Given this list of marker genes CLIC6, SPINK1, APOE, NR6A1, CA4, S100G, AFP, SLC2A3, APOOL, TTR, APOA1, EMB, TCFL5, KRT18, SLC2A1, LGMN, APOM, here is a description of the gene set: from publication van de Sluis B, Muller P, Duran K, Chen A, Groot AJ, Klomp LW, Liu PP, Wijmenga C (PMID 17371845) species: Mus musculus Human Gene Set: VANDESLUIS_COMMD1_TARGETS_GROUP_4_UP Genes up-regulated in 9.5 days post coitus (dpc) embryos with COMMD1 knockout and in normal 8.5 dpc embryos compared to normal 9.5 dpc embryos. COMMD1 (previously known as MURR1) belongs to a novel family of proteins termed the copper metabolism gene MURR1 domain (COMMD) family. The 10 COMMD family members are well conserved between vertebrates, but the functions of most of the COMMD proteins are unknown. We recently established that COMMD1 is associated with the hepatic copper overload disorder copper toxicosis in Bedlington terriers. Recent in vitro studies indicate that COMMD1 has multiple functions, including sodium transport and NF-kappaB signaling. To elucidate the function of Commd1 in vivo, we generated homozygous Commd1 null (Commd1(-/-)) mice. Commd1(-/-) embryos died in utero between 9.5 and 10.5 days postcoitum (dpc), their development was generally retarded, and placenta vascularization was absent. Microarray analysis identified transcriptional upregulation of hypoxia-inducible factor 1 (HIF-1) target genes in 9.5-dpc Commd1(-/-) embryos compared to normal embryos, a feature that was associated with increased Hif-1alpha stability. Consistent with these observations, COMMD1 physically associates with HIF-1alpha and inhibits HIF-1alpha stability and HIF-1 transactivation in vitro. Thus, this study identifies COMMD1 as a novel regulator of HIF-1 activity and shows that Commd1 deficiency in mice leads to embryonic lethality associated with dysregulated placenta vascularization.